The following is a description of a gene set: studied in species Mus musculus Mouse Gene Set: GOBP_NEGATIVE_REGULATION_OF_UBIQUITIN_DEPENDENT_PROTEIN_CATABOLIC_PROCESS Any process that stops, prevents, or reduces the frequency, rate or extent of ubiquitin-dependent protein catabolic process., and this is the list of marker genes: Psen2, Rps7, Rpl5 (NCBI Gene Id 19983), Fhit, Csnk2b, Bag5, Bag6, Hipk2, Map1a, Phf20l1 (NCBI Gene Id 239510), Styx (serine/threonine/tyrosine interaction protein), Clec16a, Senp1, Ogt, Prmt6, Taf9, Nop53, Shh, Anks1, Svip, Psen1, Usp7, Ccar2, Sufu, Csnk2a2, Wac (WW domain containing adaptor with coiled-coil), Eif3h, Uchl5, Qrich2, Pabpn1l, Ubxn1 (NCBI Gene Id 98173), Park7, Usp38, Pbk, N4bp1, Usp14, Cdkn2a, Hsp90ab1, Usp26, Ttc36, Sgta, Mtm1, Pdcl3, Caml, Wnt1, Tlk2, Rybp-ps, Hfe, Rpl11, Rybp, Rpl23, Usp9x, Styx-ps, Klhl40, Pml, Smarcc1, Usp5, Ddrgk1, Gipc1, Trim39